Given this list of marker genes USF3, CFAP418, LMNB2, SPIDR, TTC8, TMEM270, PLIN1, BBS10, SETBP1, ATM, SDHB, GNRH1, PANX1, RFC2, PIK3R1, IFT74 (NCBI Gene Id 80173), LARS2, AR, NCF1, POLR3H, FOS, BBS1, AKT1, SOX9, CYP19A1, GTF2I, SOX3, PAX6, LEPR, HFM1, EIF4H, FKBP6, MKS1, MID1, WDPCP, CYP17A1, BBS5, STOX1, FOXL2, GNRHR, CLIP2 (CAP-Gly domain containing linker protein 2), FIGLA, SLC37A4, DMRT1, ALG9, CYB5A, BAZ1B, BBS7, MSX1, SRY, VAMP7, FGFR1, CIDEC, STX1A, MSH3, LIMK1, BBIP1, ERAL1, PROK2, HS6ST1, OFD1, CPLX1, SPRY4, SCLT1, BMP15, DHX37, CEP290, MT-CYB (NCBI Gene Id 4519), SDHC, AGPAT2, CEP19, NR0B1, NUP107, GTF2IRD1, IFT172, KLLN, FGF8, MCM8, F7 (NCBI Gene Id 14068), WWOX (WW domain containing oxidoreductase), ELN, LEP, NDNF, PIK3CA, PTPN11, TRIM32, SDCCAG8, GTF2IRD2, MKKS, HROB, KISS1, CYP11B1, CORIN, NHLH2, LZTFL1, POR, SDHD, CAVIN1, BBS12, TUBB8, C14orf39, TBX1, KISS1R, CTBP1, VPS37D, FLT1, DHH, PLAAT3, TACR3, PSMC3IP, NSD2, NSMF, STAG3, FSHR, FGF17, GATA4, TAC3, PDE11A, NPHP1, PTEN (phosphatase and tensin homolog), TBL2, PRLR, LHB, BBS2, BSCL2, WDR11, DNAJC30, GNAS, SEC23B, METTL27, HNF1A, CBX2, PATL2, NOBOX, PHKA2, MMP14, PIGG, ZFPM2, BBS9, PHKG2, ARL6, ESR1, DUSP6, TRPV6, LETM1, PMM2, PRKAR1A, WT1, CHD7, AKT2 (NCBI Gene Id 208), NELFA, IFT27, PPP1R12A, SETD2, SCAPER, MAP3K1, WEE2, MRPS22, NR5A1, LIPE, BUD23 (BUD23 rRNA methyltransferase and ribosome maturation factor), CLPP, ANTXR2, ZSWIM7, PROKR2, ALMS1, BBS4, LMNA, CAV1, TP63, ZPR1, MSH4, INSR, BNC1, MMP2, PPARG, NTHL1 (NCBI Gene Id 4913), PHKB, HARS2, STK11, here is a description of the gene set: Human Gene Set: HP_ABNORMAL_OVARIAN_MORPHOLOGY studied in species Homo sapiens Abnormal ovarian morphology